The following is a description of a gene set: The chemical reactions and pathways involving flavonoids, a group of water-soluble phenolic derivatives containing a flavan skeleton including flavones, flavonols and flavanoids, and anthocyanins. studied in species Homo sapiens Human Gene Set: GOBP_FLAVONOID_METABOLIC_PROCESS, and this is the list of marker genes: UGT1A9, SULT1A1, SULT1A4, SULT1B1, CYP1A1, UGT1A3, UGT1A7, LCT, SULT1A3, POR, UGT1A1, SULT1C4, UGT1A10, UGT1A8